The following is a description of a gene set: Human Gene Set: GSE12845_IGD_POS_BLOOD_VS_NAIVE_TONSIL_BCELL_UP studied in species Homo sapiens B cells from human tonsil and blood were sorted using flow cytometry. The human samples were processed immediately ex-vivo using markers for known B cell subsets. Genes up-regulated in comparison of IgD+ peripheral blood B cells versus IgD- naive tonsil B cells. from publication Longo NS, Lugar PL, Yavuz S, Zhang W, Krijger PH, Russ DE, Jima DD, Dave SS, Grammer AC, Lipsky PE (PMID 19023113), and this is the list of marker genes: PLD3, CD24, ANKEF1, TRIM23 (tripartite motif containing 23), ADA2, GTF2E1, RNF141, SNX1, H2BC5, CXCR4, FAM50B, CCDC28A, ETS2, NCOR1, TATDN2, CD28, DYRK4, CARF, GLT8D1, IGLL3P, CLSTN1, CDK14, WASHC4, EXOC3, GGNBP2, KLHL9, RAMP1, H1-3, KIFAP3, ABCA7, ZNF767P, SPIB, PILRB, TBX2, NDUFS2, CD81, LIMS2, TMEM147, ITFG2, H2BC21, EMILIN2, ACBD4, HCK, SLC7A7, S100A4, ZNF428, CCR7, GON4L, NEB, ATP10D, NRGN, KLRC3, CRYBG1, SUPT20H, TP53, TFR2, NEK9, GPR171, FLOT2, TPP2, ARMH3, NEURL1, HNRNPU, IGHD, DBP, RAB4B, DPYSL2, OGT, EIF3E, SMARCAL1, BTG2, RAB11A, CYB5A, POMT2, KIAA0040, H2BC9, UBTF, ZNF248, PCNT (NCBI Gene Id 9346), FLNA, SLC48A1, PIM2, PRMT2, KLF8, TCL1B, CST1, DEXI, TSC22D1, DDX18, NSUN5P1, WRAP73, VCL, HK3, H4C8, MSL1, ITGB7, MRM1, H4C11, NBPF10, RPL10A, MCPH1, FARP2, PIEZO1, IFNGR2, MX1, MACROD1 (NCBI Gene Id 28992), KCTD7, MARCHF5, CBR4, BCKDHB, ZNF232, PRKAG1, H2BC12L, H2BC7, AP1G2, MAGEF1, DOP1B, PALS2, CTSS, H3C8, GLS, ID3, RANBP3, NAGA, SMIM27, TGDS, NUP43, H2BC6, AKR1C3, HDAC5, TRIB2, RNF126, PODXL2, CSTB (cystatin B), CD2, DSG1, MLLT1, HMGN4, HSPA1A, RNF126P1, RNF146, NPLOC4, MEGF6, HSDL2, TBXA2R, RHOB, ICAM2, PCID2, MEGF8, TIMP2, ABHD10, ZNF692, ABCC10, PYCR3, NDST1, MARF1, RMND5B, MGAT3, FMO5, MXD4, SERPINI1 (NCBI Gene Id 5274), AP3B1, AHNAK, TMEM134, TOP6BL, PLEK, ZNF302, ELMO2, ARHGAP1, MEOX1, RORC, LILRB4, SMIM7, WDR7 (NCBI Gene Id 23335), SNHG32, FAM131B, CLPP, EPN2, ATP8A1, ANXA4, POLDIP3 (DNA polymerase delta interacting protein 3), ARFGAP2 (NCBI Gene Id 84364), UIMC1, FNDC11, TAGLN2, UCP2, KLRK1, ATP11A, IER5, MRPL57, CAPN10, AKR7A3, PARP12, TARBP2, CDHR5